The following is a description of a gene set: Either of the ends of a mitotic spindle, a spindle that forms as part of mitosis, where spindle microtubules are organized; usually contains a microtubule organizing center and accessory molecules, spindle microtubules and astral microtubules. studied in species Mus musculus Mouse Gene Set: GOCC_MITOTIC_SPINDLE_POLE, and this is the list of marker genes: Stag1 (NCBI Gene Id 20842), Ypel5, Smc3, Katna1, Kif20b, Cdk5rap2, Smc6, Plk1, Git1, Katnbl1, Stag2, Lzts2, Rmdn3, Numa1, Rmdn2, Mapre1, Rmdn1, Fam161a, Aspm, Spag5, Ttc28, Rae1, Tnks, Cntrl, Map10, Mad1l1, Nsmce1, Aurka, Or2a7, Hsf1, Eml1, Fam83d, Aurkb, Mapkbp1, Kat5, Nin, Smc1a, Bccip, Gpsm2, Arhgef7, Ik